Given this list of marker genes DDX21, BAZ2A, ACTR6, SMARCA5, NOP53, MACROH2A2, CREBBP, DEDD, MACROH2A1, FLNA, MAF1, here is a description of the gene set: species: Homo sapiens Human Gene Set: GOBP_NEGATIVE_REGULATION_OF_TRANSCRIPTION_BY_RNA_POLYMERASE_I Any process that stops, prevents, or reduces the frequency, rate or extent of transcription mediated by RNA polymerase I.